The following is a description of a gene set: species: Homo sapiens Formation of the embryonic stem cell BAF (esBAF) complex Human Gene Set: REACTOME_FORMATION_OF_THE_EMBRYONIC_STEM_CELL_BAF_ESBAF_COMPLEX, and this is the list of marker genes: BCL11A, SMARCA4, SMARCC1, BCL7B, SS18, SMARCE1, BCL7A, ACTL6A, SMARCB1, SMARCC2, ACTB, DPF2, SMARCD3, BCL7C, PHF10, SMARCD2, ARID1A, SMARCD1, BCL11B